Given this list of marker genes NOS1AP, NOS1, MIR328, CASQ2, KCNE3, FLNA, MIR133A1, MIR1-1, RNF207, here is a description of the gene set: Any process that modulates the frequency, rate or extent of membrane repolarization during cardiac muscle cell action potential. Human Gene Set: GOBP_REGULATION_OF_MEMBRANE_REPOLARIZATION_DURING_CARDIAC_MUSCLE_CELL_ACTION_POTENTIAL species: Homo sapiens